Given this list of marker genes PI3, SERPINE2, KLK14, TACR1, AVPR1A, ACVR2A, ABAT, ADA (NCBI Gene Id 100), OXT, P2RX1, P2RY1, SEMG1, EDDM3A, DDO, EDNRB, TAC1, here is a description of the gene set: studied in species Homo sapiens The act of sexual union between male and female, involving the transfer of sperm. Human Gene Set: GOBP_COPULATION